The following is a description of a gene set: Genes up-regulated in BJ cells (forskin fibroblasts) upon overexpression of the most abundant alternative splicing forms of MDM2, HDM2-A and HDM2-B, off a retroviral vector. The HDM2 oncoprotein is a cellular inhibitor of p53 and is frequently deregulated in human cancer. However, the HDM2 gene encodes alternatively spliced variants whose functional significance is poorly understood. We had previously reported the detection of alternative HDM2 forms in Hodgkin's lymphoma (HL)-derived cell lines. Here, we have cloned several of these transcripts, including the previously described HDM2-A, -B and -C (which encode the COOH terminus of HDM2), and two novel variants (HDM2-HL1 and -HL2) containing a complete p53 interaction domain. Real-time PCR assays demonstrated that HDM2-A and -B were selectively expressed by HL cell lines and primary tumors, compared with their non-neoplastic counterparts. In transient transfection experiments, alternatively spliced HDM2 isoforms were partially or totally localized within the cytoplasm. HDM2-HL2 was able to inhibit transactivation of a p53-inducible reporter construct and induced a partial relocalization of p53 to the cytoplasm. Expression of HDM2-A and -B caused the activation of p53/p21 and induced growth arrest in primary cells, but also increased the expression levels of cyclins D1 and E. Other possible genes regulated by HDM2-A and -B were identified using cDNA microarray technology. These results imply that HDM2 isoforms may have multiple effects on cell cycle control, and provide insight into the mechanisms through which these molecules contribute to tumorigenesis. species: Homo sapiens Human Gene Set: SANCHEZ_MDM2_TARGETS from publication Sánchez-Aguilera A, García JF, Sánchez-Beato M, Piris MA (PMID 16331255), and this is the list of marker genes: CCND1, FCGRT, INHBB, CDKN1A, RNF113A, ADIRF, H2BC21, TIMP1, H2AC18, IL1RN, LRMDA, CLIP3, RABAC1, IGFBP6, IL13RA2